The following is a description of a gene set: Human Gene Set: PAX4_01 studied in species Homo sapiens Genes having at least one occurrence of the motif NGNVGTCANGCGTGNNSNNYN in the regions spanning 4 kb centered on their transcription starting sites. This matches the PAX4 transcription factor binding site V$PAX4_01 (v7.4 TRANSFAC)., and this is the list of marker genes: KLC2 (kinesin light chain 2), SSH2, RANBP1, TMEM8B, H1-10, PNKD, RING1, ACOX2, PABPC4, RBP4, GALNT10, MEGF8, NRDC, CNTFR, DNAJB2, IRX2, GNB2, C1QL2, MRM1, ZCCHC9, NFKBIA, PDE4D, PLEKHH3, LIN28A (lin-28 homolog A), HOXA7, JADE2, EIF4A1, PLAGL2, FAM117B, RAB43 (NCBI Gene Id 339122), VGF, IL17B, DNAJB5, ODR4, AP1B1, PABPC1, TRMT2A, ZNF654, SART3, CDK9, PLAGL1, AAMP, CDX4, SALL1, C1QL1, PRKAG1, CPT1B, PHF12, ATOH1, CACNA1D (calcium voltage-gated channel subunit alpha1 D), SP4, TBCB, CHKB, DLG3, RBBP6, NR0B2, FGF6, PDGFB, ABHD2, KLF14, CTDSP1, ACSL3, PACS1, ADIPOR2, SND1, PRDM1, DTX1, KLF13, FBXL19-AS1, FEZF2, PTCH1, ZNF827, WNT10A, NR4A3, AMFR, KPNB1, XPO1 (NCBI Gene Id 7514), BCL11A, ZFYVE27, PLEKHA1, CELF6, RPS6KA4, TIGD6, HEXIM2, C1orf21, PTPRG, SAP130 (Sin3A associated protein 130), AGO2, NFATC4, HOXA10, NTRK3, POU3F3, GTF3C2, TPM1, ANKMY2, MAPRE1, GOLGA8IP, SPRY2, ANGPT1, CYSTM1, HOXB1, PSIP1, DDIT3, DGKZ, NUFIP2, EVX1, TAF5, PER2, PTGES3, EED, EIF5A, LRP2, DNAJC11, SORCS3, PBX1, LRP1, GSE1, STX1B, NKX2-1, GPR37L1, MAGI1, PHF21A, NCDN, LBX1, PHF21B (PHD finger protein 21B), LHFPL1, CTF1, SRPK3, NOB1, FAM78A, BPIFB4, CIZ1, PHKB, SEMA3B, SIK2, NAE1, ITGB8, ATG16L1, USP39, TMEM256, TFAP4, SLC30A5 (NCBI Gene Id 79021), SMAD1, TAF11, TNXB, MXI1, ZDHHC5, NIPBL, PHF23, MIR17HG, ASB7, TMEM187, CIC, MAPT, MXD4, MIR22HG, CDK16, PTPN23, HOXA1, FGD1, NECAB3, MMP11, SLC16A10, FAM76A, IWS1, GK (glycerol kinase), NRXN1, TPR, HIF3A, SPTAN1, TRERF1, COL27A1, LINS1, CCNI, JARID2, LEMD2, CPNE1, SMG1, PAQR4 (NCBI Gene Id 124222), ZNF777, PIK3CD, CREBZF, PDZRN4, POFUT1, CTBP2, PGF, E2F1, IL1RAPL1, TMED2, CCDC177, RNF19B, SCUBE3, YWHAZ, HS3ST2, ZNF593, SLC25A28 (solute carrier family 25 member 28), NF2, MNT, EFNA5, SLC35B1, GRIN2A, UBTF, PICALM, ARHGAP30, LARP4, ETV5, PCF11, NEUROG1, GTF2IRD1 (GTF2I repeat domain containing 1), HES1, ESRRA, RNF10, DAAM2 (dishevelled associated activator of morphogenesis 2), ITFG1, ELAVL1, SLC4A1, GADD45G, HOXD10, RBMS3, TRIM3, LYST, CDC73, TBC1D22A, CBX6, MEX3B, SLC38A3, EFHD1, FAM222B, SYNCRIP, DLL4, KLF10, OAZ2, FBXL19, BAG6, BDNF (brain derived neurotrophic factor), CDH16, RRAS, CDX1, HOXB6, IRX2-DT, ARHGEF12, HMGN2, ANKS1A, ZHX2, DDX17, MAML1, PHF20L1, SUOX, WDR81, ADAMTSL1, DNM1, ARF6, KCNK13, JUND, ZIC2, FBXW4, MAPK10, GRIK1, ISCU, CAPN5, CORO6, MAF, FAM162A, HNRNPR, RAB33A, GIGYF2, FBXO36, ACTC1